The following is a description of a gene set: from publication Hasina R, Pontier AL, Fekete MJ, Martin LE, Qi XM, Brigaudeau C, Pramanik R, Cline EI, Coignet LJ, Lingen MW (PMID 16205646) Human Gene Set: HASINA_NOL7_TARGETS_DN Genes down-regulated in SiHa cells (cervical carcinoma) by stable expression of NOL7 off a plasmid vector. species: Homo sapiens Cervical cancer is associated with human papilloma virus infection. However, this infection is insufficient to induce transformation and progression. Loss of heterozygosity analyses suggest the presence of a tumor suppressor gene (TSG) on chromosome 6p21.3-p25. Here we report the cloning NOL7, its mapping to chromosome band 6p23, and localization of the protein to the nucleolus. Fluorescence in situ hybridization analysis demonstrated an allelic loss of an NOL7 in cultured tumor cells and human tumor samples. Transfection of NOL7 into cervical carcinoma cells inhibited their growth in mouse xenografts, confirming its in vivo tumor suppressor activity. The induction of tumor dormancy correlated with an angiogenic switch caused by a decreased production of vascular endothelial growth factor and an increase in the production of the angiogenesis inhibitor thrombospondin-1. These data suggest that NOL7 may function as a TSG in part by modulating the expression of the angiogenic phenotype., and this is the list of marker genes: CD55, CD53, VEGFA, ADGRE5, SDC2, EGFR, MET, TGFBR1, EML1, SDC1, JAG1, AIMP1, ANGPT1